The following is a description of a gene set: Genes up-regulated in UB27 cells (osteosarcoma) at 12 hr after inducing the expression of a mutated form of WT1. studied in species Homo sapiens The Wilms' tumor suppressor gene (WT1) encodes a zinc finger transcription factor that is vital during development of several organs including metanephric kidneys. Despite the critical regulatory role of WT1, the pathways and mechanisms by which WT1 orchestrates development remain elusive. To identify WT1 target genes, we performed a genome-wide expression profiling analysis in cells expressing inducible WT1. We identified a number of direct WT1 target genes, including the epidermal growth factor (EGF)-family ligands epiregulin and HB-EGF, the chemokine CX3CL1, and the transcription factors SLUG and JUNB. The target genes were validated using quantitative reverse transcriptase-polymerase chain reaction, small interfering RNA knockdowns, chromatin immunoprecipitation, and luciferase reporter analyses. Immunohistochemistry of fetal kidneys confirmed that a number of the WT1 target genes had overlapping expression patterns with the highly restricted spatiotemporal expression of WT1. Finally, using an in vitro embryonic kidney culture assay, we found that the addition of recombinant epiregulin, amphiregulin, CX3CL1, and interleukin-11 significantly enhanced ureteric bud branching morphogenesis. Our genome-wide screen implicates WT1 in the transcriptional regulation of the EGF-family of growth factors as well as the CX3CL1 chemokine during nephrogenesis. Human Gene Set: KIM_WT1_TARGETS_12HR_UP from publication Kim HS, Kim MS, Hancock AL, Harper JC, Park JY, Poy G, Perantoni AO, Cam M, Malik K, Lee SB (PMID 17430890), and this is the list of marker genes: RAB13, RUNDC3B, CALCOCO1, TRIB2, SOX9, ANKRD13C-DT (NCBI Gene Id 11147), RASSF7, ATP1B1, SERPINE1, TIMP3, BAK1, KIF5B, HSPA6, HEG1, ITGB5, MN1, HSPA1B, PDGFRA, JUNB, DAB2, KCNK1, CHRNA1, VPS37B, TMEM255A, PLCD1, HBEGF, LRP4, HSPA12A, FERMT2, IL10RB, ZCCHC24, CDC42EP4, NPPB, MYCN, TM4SF1, LBH, PEA15 (NCBI Gene Id 8682), SEPTIN9, NOX4, ID4, CXCL14, PRKCH, SMAD3, SH3BP5, LGR4, CX3CL1, NFAT5, MYL9, IL1RAP, RBFOX2, PPP3CA, ARHGDIA, PIK3R3, CDC42EP3 (NCBI Gene Id 10602), NYNRIN, HTRA1, ADORA1, OXR1, HSPH1, PLAU, ATP9A, ULBP2, CHRNA3, GLI2, HNRNPL, MTDH, AAK1, TLN2 (NCBI Gene Id 83660), KLF9, WT1, DDIT4, ADGRG1 (adhesion G protein-coupled receptor G1), CDR2L, ST8SIA1, FGFR3, C1orf116, AMPD2, TBC1D2, FGFR1, HSPA1A, TLE3, CREB3L2, MTUS1, AREG, FGF1 (NCBI Gene Id 29961), SUPT6H, CA12, MICALL1, PTPN20, ENDOD1, BLCAP, MYLK, P4HA2, GPR183, SLC20A1, CASK, BTN3A3, PLAT, CRY1, BHLHE41, SRSF6, TNS3, SCNN1D, PCDHGC3, GDF15, PODXL, MED13L, DLGAP5, TULP3, IFIT1, TNFRSF11B, ZMIZ1, CSF1, PSD3, SLC10A3, TUBA4A, SERPINH1, SNAI2, YPEL5, ENO2, P4HA1, CREB3L1, CSPG4, MYO18A, ADM, TBX3, GRB10, ZMYND8, FHOD1, FZD7, MYBL1, TAF6L, PJA2, DOK4, EPS8, CSDC2, COPB1, ABAT, MYOF, SON, IL11, DNAJB1, MSX1, PLEKHO1, ATP2B4, ACSL1, KIF3C, ZSCAN31 (zinc finger and SCAN domain containing 31), TPST2, AQP1, CS, SLC35G2, RHOQ, TMPRSS3, OGA (NCBI Gene Id 23375), ZNF702P, GGT1, THY1, DDR1, UBE2J1, SYNC, EPOR (NCBI Gene Id 2057), SLC17A7, RIPOR1, ZNF395, GFPT1